Given this list of marker genes AEBP1, F2, SERPINC1, MTHFR, TGFB2, F13A1, HABP2, here is a description of the gene set: Repeated episodes of inflammation of a vein associated with venous thrombosis (blood clot formation within the vein). species: Homo sapiens Recurrent thrombophlebitis Human Gene Set: HP_RECURRENT_THROMBOPHLEBITIS